Given this list of marker genes SLC28A2, SLC29A2, SLC29A3, SLC25A6, SLC25A4, SLC29A4, SLC25A5, SLC28A3, SLC29A1, ARL2, ARL2BP, SLC28A1, here is a description of the gene set: Transport of nucleosides and free purine and pyrimidine bases across the plasma membrane Human Gene Set: REACTOME_TRANSPORT_OF_NUCLEOSIDES_AND_FREE_PURINE_AND_PYRIMIDINE_BASES_ACROSS_THE_PLASMA_MEMBRANE studied in species Homo sapiens